Given this list of marker genes NACA4P, FBXO36, LNCTSI, EPRS1, TIMMDC1-DT, PRKCZ, AHI1, MIR4664, CORO1C, DMAC2L, MST1P2, USP54, MT-RNR1, ATL2, TMED4, RAB5IF, MT-TE, CFDP1, RNA5SP448, RNF121, BRF1, TM4SF1-AS1, ZNHIT2, NME1, RPTOR (regulatory associated protein of MTOR complex 1), PRKCH, RNU6ATAC32P, SMARCD2, RANBP1, MTCO3P12, CUEDC1, MRPS33, SETD5, PSMD2, LAMB1, CMC1, PITPNM2, ZNF7, MBL2, CLCN3, DHX8, RAB36, DNM2, PSMD14, EFHB, KDM4B, CCDC71, PSMD14-DT, LAD1, ARFRP1, OTUD6B, CENATAC, CCDC174, RPS6KA1, CCDC146, SLIRP, LAS1L, SIPA1L2, EFCAB13-DT, MDM2, ACTN1, CHMP4B, MRPS28 (mitochondrial ribosomal protein S28), MRPL20, SH3TC2-DT, BRCA1, RPSAP31, NRP1, SLC25A16, HIKESHI, RABGEF1P1, CCNB2, LINC02380, ENSG00000212273, RPRD1B, CDK4, HSD17B8, ZNF341-AS1 (NCBI Gene Id 101929746), GPATCH3, MTND5P11, FCHSD2, C3, SMAD6, PLD1, TM4SF1, NCF2, TINAGL1, NUP37, GFM1 (G elongation factor mitochondrial 1), CLASP1, NDUFAF6, RPS6KB1, RPL12P38, SLC25A34, USP48, CDKL1, TRIB1, MIR584, HDDC2, ADGRF4, LRRC27 (NCBI Gene Id 92295), SUN1, SERINC2, RNA5SP320, TTC12-DT, STOML2, COA1, RSPH14, PDE4A (NCBI Gene Id 5141), DNAJC14, CNOT2, TXNIP, PARN, SLC25A6, SMIM31, RRP12 (ribosomal RNA processing 12 homolog), ADGRG6, ALKBH1, NME1-NME2, INPP4B, FZD5, SRFBP1, LIX1L-AS1, YOD1, EXOSC4, PPP2R5A (protein phosphatase 2 regulatory subunit B'alpha), SPRED2, PARPBP, EGLN3, XNDC1N, MT-TT, VTRNA1-2, ZGPAT, BAZ2B, LINC03129 (NCBI Gene Id 84214), PWWP2A, TTI1, TRMT2A, GBA1, INTS4, FUZ, TRAF1, TMX1, MED25, ANXA11, PPIF, ZHX1, MCAM, SPEF1 (sperm flagellar 1), PHB1, SYBU, DAAM1, GHR, SCAP, SP2, SETD4, LINC01151 (NCBI Gene Id 104266958), DAZAP1, ARHGAP24, PARL, VAV1, MT-TF, CROCCP2, CNOT9, BSDC1, TTLL12, HEMK1, ABHD17B, LINC01596, KRIT1, ESPNP, POLG2, ERCC1, FAM185BP, SYNC, ZFR, MAP3K7CL, SMYD5 (NCBI Gene Id 10322), PRRG2, MGLL, UBE2G2, GIPR, TUBD1, TTC12, USP37, TMEM198B, LINC01424, METTL17, MTHFD1L, DUX4L18, RCC1, KCNN4, HUS1, C9orf85, MAPRE3, TLE4, PGAM1, UBALD2, ZNF3 (zinc finger protein 3), CENATAC-DT, FOSB, VDAC2, NOSIP, ANKIB1, AFDN-DT, TRIM46, SRC, GDE1, FAM83H, KRTCAP2, UGT2B7, FHIP1B, TTI2, ELP3, PLEKHM1, AFDN, COL8A2 (NCBI Gene Id 1296), IQANK1, ZHX1-C8orf76, KLHL4, OTUD6B-AS1, TIMMDC1, PRANCR, TRIP12, LMO7, MIR638, SRGN, TNIP2 (NCBI Gene Id 91017), BLOC1S2, RBM8A, STX7, AMPD2, METAP1, here is a description of the gene set: Genes containing one or more binding sites for (DNMT1) in their promoter regions (TSS -1000,+100 bp) as identified by GTRD version 20.06 ChIP-seq harmonization. from publication Yevshin I, Sharipov R, Kolmykov S, Kondrakhin Y, Kolpakov F (PMID 30445619) Human Gene Set: DNMT1_TARGET_GENES studied in species Homo sapiens